The following is a description of a gene set: The process in which the anatomical structures of the outflow tract septum are generated and organized. The outflow tract septum is a partition in the outflow tract. species: Mus musculus Mouse Gene Set: GOBP_OUTFLOW_TRACT_SEPTUM_MORPHOGENESIS, and this is the list of marker genes: Bmpr2, Dvl3, Parva, Nrp2, Zfpm2, Tbx20 (NCBI Gene Id 77243), Smad6, Nkx2-5, Lrp2, Bmpr1a (bone morphogenetic protein receptor, type 1A), Msx2, Bmp4, Tbx1, Sema3c, Eng, Vangl2, Tgfb2, Robo1, Fgfr2 (fibroblast growth factor receptor 2), Smad4, Nrp1, Tgfbr2, Acvr1, Gata6, Tbx2, Fgf8, Robo2, Isl1